Given this list of marker genes Nkx2-2, Tyms, Nkap, Negr1, Serpinc1, Cmya5, Ppp4r1, Xbp1 (X-box binding protein 1), Pramel3c, Deptor, Prr7, Prss30, Slamf6, Slc2a13 (NCBI Gene Id 239606, solute carrier family 2 (facilitated glucose transporter), member 13), Dglucy, Dennd5a, Tmem30a, Vcf1, Them6, Insyn2b, Pramel3d, Dmd, Zfp467, Btaf1, Zfp946, Dcaf11, Myb, Gsk3a, Ezr (ezrin), Suco, Pramel3b, here is a description of the gene set: Mouse Gene Set: MIR_7650_5P Genes predicted to be targets of miRBase v22 microRNA mmu_miR_7650_5p in miRDB v6.0 with MirTarget v4 prediction scores > 80 (high confidence targets). from publication Chen Y, Wang X (PMID 31504780) species: Mus musculus